Given this list of marker genes TTC7A, CARD11, CYBC1, FERMT1, STXBP2, STAT1, ACADVL, LRBA, DOCK2, PIK3CD, TGFB1, CIITA, EDNRB, SREBF1, MASP2, GPIHBP1, POLA1, NLRC4, DEF6, IVNS1ABP, STX11, PIGY, ELANE, MAP3K7, ECE1, NCF4 (NCBI Gene Id 4689), IL10RB, BCL10, FASLG, DCLRE1B, TNFAIP3, RET, PRF1, BACH2, HPS1, GDNF, ZAP70, FH, IL37, ERBB3, MYH11, SEMA3D, NOP10, ERBB2, SMO, CARD8, SYK, CASP10, PSTPIP1, RTEL1, ATP7A, GPR35, UNC13D, XIAP, LYN, DKC1, SEMA4D, SEMA3C, PLCG2, SLC37A4, IL6, WAS, EDN3 (NCBI Gene Id 1908), ELF4 (E74 like ETS transcription factor 4), SHARPIN, SKIC2 (SKI2 subunit of superkiller complex), DOCK11, FCHO1, ABCD1, IL10RA, PSMB10 (proteasome 20S subunit beta 10), OPLAH, NOD2, TCF4, INAVA, SKIC3, MST1, FCN3, PIK3CG, FOXP3, FAS, CARMIL2, NRTN, here is a description of the gene set: Colitis Colitis refers to an inflammation of the colon and is often used to describe an inflammation of the large intestine (colon, cecum and rectum). Colitides may be acute and self-limited or chronic, and broadly fit into the category of digestive diseases. Human Gene Set: HP_COLITIS studied in species Homo sapiens